Given this list of marker genes Zeb2, Spred3, Spry1, Spred2, Fgf2, Spry2 (sprouty RTK signaling antagonist 2), Cdkn1c, Cdkn1b, Spred1, Foxe3, here is a description of the gene set: Any process that modulates the frequency, rate or extent of lens fiber cell differentiation. Mouse Gene Set: GOBP_REGULATION_OF_LENS_FIBER_CELL_DIFFERENTIATION studied in species Mus musculus